Given this list of marker genes AEN, RPL26, PHLDA3, SIRT1, TAF9B, PPP2R5C, MARCHF7, MIF, TOPORS, HIPK1, ATAD5, IFI16, SHISA5 (shisa family member 5), TP73, BCL2, KDM1A, HIPK2, BRCA2, BCL3, NUPR1, SNW1, MSH2, ING2, PML, DYRK2, USP28, TMEM109, DDIT4, BAG6, ELL3, CD74, TAF9, CDIP1, ZNF385A, BBC3 (BCL2 binding component 3), CDKN1A, TP53, CD44, URI1, TRIAP1, TP63 (NCBI Gene Id 8860), EP300, HNRNPK, RPS27L, CHEK2, PYCARD (NCBI Gene Id 29108), MUC1, BCL2L12 (BCL2 like 12), here is a description of the gene set: Human Gene Set: GOBP_INTRINSIC_APOPTOTIC_SIGNALING_PATHWAY_IN_RESPONSE_TO_DNA_DAMAGE_BY_P53_CLASS_MEDIATOR species: Homo sapiens The series of molecular signals in which an intracellular signal is conveyed to trigger the apoptotic death of a cell. The pathway is induced by the cell cycle regulator phosphoprotein p53, or an equivalent protein, in response to the detection of DNA damage, and ends when the execution phase of apoptosis is triggered.